Given this list of marker genes SDHC, SDHD, SDHB, SDHAF2 (NCBI Gene Id 54949), SDHA, here is a description of the gene set: Human Gene Set: GOBP_MITOCHONDRIAL_ELECTRON_TRANSPORT_SUCCINATE_TO_UBIQUINONE studied in species Homo sapiens The transfer of electrons from succinate to ubiquinone that occurs during oxidative phosphorylation, mediated by the multisubunit enzyme known as complex II.